The following is a description of a gene set: part of: Transcriptional Regulation by MECP2 studied in species Homo sapiens Reactome Pathway: MECP2 regulates transcription of genes involved in GABA signaling MECP2 regulates expression of several genes involved in GABA (gamma-aminobutyric acid) signaling. Transcription of GAD1 (GAD67) and GAD2 (GAD65) genes is directly positively regulated by MECP2. GAD1 and GAD2 are components of the glutamic acid decarboxylase complex involved in production of the neurotransmitter GABA. Mice lacking Mecp2 from GABA-releasing neurons have decreased GABA levels and exhibit multiple Rett syndrome features.<p>Mecp2 deletion in mouse GABAergic parvalbumin-expressing (PV) cells, cortical interneurons playing a key role in visual experience-induced ocular dominance plasticity, does not result in Rett-like phenotype, other than defects in motor coordination and motor learning. While functions of the visual cortex are preserved in mice lacking Mecp2 in GABAergic PV cells, the visual input-induced spiking responses are decreased. Mecp2 loss impairs maturation of membrane functions of cortical GABAergic PV cells. Mecp2 may be needed for PV cell-mediated cortical GABA inhibition. Mecp2-deficient cortical PV cells show reduced mRNA levels of several genes involved in GABA signaling, such as Parvalbumin, Gad2, Calretinin, Gabra1 and Gabra2, as well as reduced levels of Glu3, a glutamate receptor subunit, and Kv3.1, a potassium channel., and this is the list of marker genes: MECP2, GAD2, GAD1